Given this list of marker genes CLCN7, SNX10, TCIRG1 (T cell immune regulator 1, ATPase H+ transporting V0 subunit a3), PRKD1, ALPL, WNT10A, GJA1, KDF1, FIG4, TNFSF11, VDR, CSTB, FERMT1, EDARADD, C1R, C1S, EDAR, COL3A1, TRAF6, CTSC, VAC14 (VAC14 component of PIKFYVE complex), here is a description of the gene set: Human Gene Set: HP_PREMATURE_LOSS_OF_PRIMARY_TEETH Loss of the primary (also known as deciduous) teeth before the usual age. Premature loss of primary teeth studied in species Homo sapiens